The following is a description of a gene set: studied in species Homo sapiens Human Gene Set: GSE20727_CTRL_VS_ROS_INH_AND_DNFB_ALLERGEN_TREATED_DC_DN Genes down-regulated in dendritic cells: control versus 2,4-dinitrofluorobenzene (DNFB) and diphenyleneiodonium (DPI). Identification of ROS induced genes on dendritic cells Dendritic cells were incubated for 15 min with or without a ROS inhibitor (DPI), washed extensively and incubated for 30 min with a chemical allergen (DNFB), hydrogen peroxide, and vehicle alone in HBSS containing DPI or vehicle. After washed extensively, the samples were post-incubated for 5.5 h with DNFB, hydrogen peroxide, or vehicle in complete culture medium containing DPI or vehicle. from publication Miyazawa M, Takashima A (PMID 22974541), and this is the list of marker genes: PGRMC2, IGHV4OR15-8, GOLGA2, TECR, SEC24C, PSMA5, CRADD, CD27, ITCH, PHGDH, ITGA6, BMP8B (NCBI Gene Id 656), GINS1, GOT1, CCNG1, KPNA2, TUBG1, ZMPSTE24, SRP72, GOLM2, SDF2L1, MRPL51, CHST12, TMEM59, MYB, KDELR3, UBN2, HMGB2, SPN, UBL4A, ARHGDIA, NBEA, SECISBP2L, FTSJ1, GOLPH3, EXT1, AARS1, EIF2AK3, LRRC8A, ATG13, HIBCH, CYB561, EIF5B, NDUFB4, MAN1A2, CDK4, SDR42E1, ZWINT (NCBI Gene Id 11130), RPUSD4, TAP1, COPB1, HEXB, BUD23, NUP62CL, TMEM41A, PSEN2, ICMT, UBXN4, ACSS1, DLGAP5, HJURP (NCBI Gene Id 55355), ZDHHC9, NEK2, PSMD14, PSMC4, IL6R, ZNRD2, JMJD8, MRPL16, SLC35E1, B4GALT2, NDUFS7, AFMID (arylformamidase), BAK1, UFM1 (ubiquitin fold modifier 1), C15orf39, AHCY, NFE2L1, PSME2 (proteasome activator subunit 2), HMBS, TMED3, PLXNA1, PRC1, MYBL2, SSNA1, PAICS, RDH10 (NCBI Gene Id 157506), PFDN6, KRTCAP2, KIF4A, CLINT1, FBXW8, SIL1, ARF4, TMEM237, PGM3, SRP68, PAM, RNF115, IFNAR1, CDK6, GMNN, PLK1, TMEM179B, ATP5F1A, TUT7, CLPTM1L, GNS, ADRM1, CFAP54, EMC7, CARS1, SMAD7, ECH1, SDHC, TMEM33, RPS6KB2, DPM3, EML5, STT3B, MKI67, UFD1, DUSP16, PRMT1, GOLPH3L, MRPS34, MND1, SUB1, YME1L1, KATNB1 (katanin regulatory subunit B1), RNF181, BCL2L11, FXN, TET1, RBM45, EMC2, USP38, CCNA2, MACIR (macrophage immunometabolism regulator), IARS1, NCAPH (NCBI Gene Id 679), ATP5MC1, KIF23, BSCL2, LIME1, MRPL37, AAAS, GPRC5D, MCFD2, PSMD3, CCNE2, H1-5, QSER1, LYSMD3, YIPF5, GOLGA3, AACS, CIB3 (calcium and integrin binding family member 3), SSR4, IPO5, IGKC, FAM177A1, CDK1, SEC61G, ASNS, UBE4A, WFS1, MAD2L1, MAGEH1, E2F2, SFXN2, CTSD, SQLE, SLFN13, TUBB4B, MGAT4A, SLC16A6, HERC2P9, MRPS15, TOP2A, PSMB5, ANLN, VSIR, DPM1, H2AC8, STOML2, SLC30A6, PLOD3, P3H1, TMEM258, TMEM147 (transmembrane protein 147), CEP152, GALNT1, GJB7, USO1, CENPA, TXN